Given this list of marker genes Fah, Fabp2, Clec10a, Aqp1, Mtarc1, Tcf19, Krt8, Akap7, Marco, Krt20, Ap1s3, Dapk2, Top1mt, Tm2d2, Tpmt, Nme4, Dnase1l1, Tspo, Ydjc, Maoa, Rnh1, Xlr3a, Upb1, Gcat, Gng10, Crtap, Il18rap, Slc39a5, F7, Khk, Qprt, Lefty1, Mfsd10, AU015836, Dhrs4 (dehydrogenase/reductase 4), Ada, Rpp40, Speg, Pdzk1ip1, Nxpe2, Mthfs, Itga6, Aldob, Nt5c3b, Camk1, Tac2, Cd5l, Gpx7, Hsd17b11, Ugt2b35, Tom1l1, P2rx4, Txnrd3, Cisd3, Ctsh, Pdk1, Zdhhc2, Ifi30, Cavin3, Timd2, Cfp, C1qb, Dhrs7, Klk8, Cfap57, Serpinb6a, Lgmn, Lgals2, Ptgr1, Sp3, Rps6ka4, Fuom, Glrx, Rabepk, Gpr155, Fcna, Cdo1, Nupr1, Myd88 (NCBI Gene Id 17874), Pitpnm1, Cd302, Ehhadh, Dleu2, Lgals3, Ugt2b34, Liph, Anxa4, Hipk3, Slc66a3, Evi2a, Acbd4, Cd82, Evc, here is a description of the gene set: Mouse Gene Set: VANLOO_SP3_TARGETS_DN Mice lacking the zinc finger transcription factor specificity protein 3 (Sp3) die prenatally in the C57BL/6 background. To elucidate the cause of mortality we analyzed the potential role of Sp3 in embryonic heart development. Sp3 null hearts display defective looping at embryonic day 10.5 (E10.5), and at E14.5 the Sp3 null mutants have developed a range of severe cardiac malformations. In an attempt to position Sp3 in the cardiac developmental hierarchy, we analyzed the expression patterns of >15 marker genes in Sp3 null hearts. Expression of cardiac ankyrin repeat protein (Carp) was downregulated prematurely after E12.5, while expression of the other marker genes was not affected. Chromatin immunoprecipitation analysis revealed that Sp3 is bound to the Carp promoter region in vivo. Microarray analysis indicates that small-molecule metabolism and cell-cell interactions are the most significantly affected biological processes in E12.5 Sp3 null myocardium. Since the epicardium showed distension from the myocardium, we studied expression of Wt1, a marker for epicardial cells. Wt1 expression was diminished in epicardium-derived cells in the myocardium of Sp3 null hearts. We conclude that Sp3 is required for normal cardiac development and suggest that it has a crucial role in myocardial differentiation. Genes down-regulated in E12.5 hearts from mice with SP3 knockout compared to the wild type organ. species: Mus musculus from publication van Loo PF, Mahtab EA, Wisse LJ, Hou J, Grosveld F, Suske G, Philipsen S, Gittenberger-de Groot AC (PMID 17923686)